Given this list of marker genes RPL26, EXOSC8, EXOSC5, BUD23, RPL29, RPL6, RPL32, RPS10 (NCBI Gene Id 6204), RPS9, RPL10A, LAS1L, WDR3, ERI1, 5.8S rRNA, RPL4, RPL27, RPS25, NIP7, NOL9, BYSL, RPL22L1, UTP3, RPL35, MPHOSPH10, PES1, RPS4X (NCBI Gene Id 6191), RPL3L, UTP14A, RPL37, 28S rRNA, RPLP0, RPL36AL, RPL3, RPS18, WDR36, RPL28, RPP25, NOP2, DDX21, RPS4Y1, RPS3A, UBA52, RPL23A, DCAF13 (NCBI Gene Id 29069), SNORD3A, KRR1, NOP56, DIS3, FAU, RPL36A, TSR1, DDX47, NOC4L, RPL7, IMP3, 18S rRNA, PNO1, RPL27A, EXOSC1, NOL6, NOB1, RPL9, RPP40, RPS19, RPL15, RPL35A, FCF1, EXOSC6, FTSJ3, RNA45S5, RIOK2, RPL13A, RPL10L, RPP21, RPL21, EMG1, RPS3, RRP9, NHP2, RIOK1, RPLP1, RPS7, EXOSC2, TEX10, TBL3, RPL5, IMP4, MTREX, WDR46, UTP14C, RPS27L, RPL10, RPL39L, RRP36, RRP1 (ribosomal RNA processing 1), RPS4Y2, RPL7A, RPSA, RPS14, RPS28, RPS27, UTP4, RPL14, C1D, 5S rRNA, WDR12, RPS6, SNU13, RIOK3, RPL34, RPS17, HEATR1, RPL11, GNL3, RPS13, UTP20, RPS2, RPP30, TSR3, RPL39, RPL31, RPS5, NOP10, TRMT112, EXOSC10, RPL22, RPS23, GAR1, RPL8, RPL24, NOL12, RPS8, RPLP2 (NCBI Gene Id 6181), ISG20L2, RPS29, XRN2, DIMT1, FBL (NCBI Gene Id 2091), RPS15A, PWP2, RPS27A, RPS21, RPP38, RPL30, CSNK1D, CSNK1E, NCL, NOP14, RPL18, PDCD11 (programmed cell death 11), UTP18, RPS20, RPL18A, RPS16, NAT10, RCL1, DDX52, RPS26, UTP25, RPL12, BOP1, DHX37, WDR18, WDR43, RPS12, RPP14, NOP58, PELP1, BMS1, EXOSC4, RPS24, THUMPD1, EXOSC9, WDR75, RPL41, RPL19, EXOSC7, RRP7A, RPS15, RPL13, EBNA1BP2, NOL11, LTV1, DKC1, RPL37A, RPS11, RPL26L1, RPL38, DDX49, UTP11, EXOSC3, UTP6, RPL36, RBM28, UTP15, RPL23, SENP3, RPL17, MPHOSPH6, here is a description of the gene set: studied in species Homo sapiens Each eukaryotic cytosolic ribosome contains 4 molecules of RNA: 28S rRNA (25S rRNA in yeast), 5.8S rRNA, and 5S rRNA in the 60S subunit and 18S rRNA in the 40S subunit. The 18S rRNA, 5.8S rRNA, and 28S rRNA are produced by endonucleolytic and exonucleolytic processing of a single 47S precursor (pre-rRNA). Transcription of ribosomal RNA genes, processing of pre-rRNA, modification of nucleotide residues within the rRNA, and assembly of precursor 60S and 40S subunits occur predominantly in the nucleolus, with a few late reactions occurring in the cytosol. part of: rRNA processing Reactome Pathway: rRNA processing in the nucleus and cytosol